Given this list of marker genes USP6, GPR50, PDE4B, AKAP5, ADD1, SPTBN1, NLGN4X, NSMF, MAGI2, PLXNC1, DLGAP1 (DLG associated protein 1), CNIH2, EIF3E, DLG1, RPS14, DLG2, DTNB, PALM (NCBI Gene Id 5064), RTN1, IGSF9, GRIK1, C1QL2, IGSF8 (immunoglobulin superfamily member 8), LRRC7, GPSM2, RPL12, SLC30A3, DAGLA, VPS35, SH3KBP1, SHISA6, SYNPO, CPEB3, LRP4, RGS7BP, HOMER3, ALS2, PTPRO, KCNH1, KALRN, GRIA3, YWHAH, GRM7, SOS1, SLC30A1, PTK2B, PLXNA4, DISC1, ABI3, ITGB1, PPP1R9B, CRTAC1, NLGN1, CASP3, GRIN1, AURKA, NCS1, CACNG8, RGS9, RPL6, LNX1, ADD3, GRID2IP, NEGR1, CAMK2D, DCC, SUMO2, GRIK3, NPTN, FRMPD2, LRRTM2, DROSHA, DGCR8, BMPR2, SYN1, ZDHHC15, FMR1, SYT9, KCNK2, NSG2, BRSK1, RPL18A, RPL8, PPP1R9A, ARHGAP32, FABP5, MIB1, SHISA8, ARC (activity regulated cytoskeleton associated protein), TAMALIN, PRKN, ATP1A1, DMTN, PDPK1 (3-phosphoinositide dependent protein kinase 1), RPLP0, ATP2B2, SLC16A7, GRIP1, AMOT, SHANK2, DLG4, DNM3, ATP7A, DBN1, GRIN2A, ELFN1, ARHGAP33, PRNP, SLC4A8, ATP1B2, ELFN2, CHRM1, RS1, LRFN4, CLSTN3, SLC6A9, SLC8A2, NECTIN3, NLGN3, ROGDI, ABL1, GPHN, SIGMAR1, CACNG7, P2RY1, P2RX3 (NCBI Gene Id 5024), PRKCG, RPS27, GRIA1, CNKSR2, DNAJC6, OPRD1, GRIN2B, TRAPPC4, ADORA1, STXBP5, DYNLL2, GOPC, CABP1, HOMER1, ANP32E, GPER1, CALB1, BNIP3, ADGRB3, NLGN4Y, ADGRA1, YWHAZ, CACNG5, ADCY1, SYT11, CPEB4, ARF1, ANKS1B, CACNA1C, LRRC4B (leucine rich repeat containing 4B), CHD4, ATP1A3, LRRC4, LRFN2, ZDHHC2, NETO1, ITGA8, GRM1, NCK2, RPL38, PTEN, PRRT2, TANC1, RYK, CLSTN2 (NCBI Gene Id 64084), LZTS3, FBXO45, RPL30, SRGAP2, DNAJB1, EGLN1, SLC39A3, TMEM108, ADCY8, SLC1A1, CTNNA2, BACE1, PLPPR4, CALCA, GRIN2C, RTN2, IGSF9B, SYN2, PSD3, GRIA2, LRFN1, CAMK2G, CACNG4, RPL10A, ERBB4, USP8, C1QL1, SEMA4C, GRIN3B, PPP3R1, BCR, NRCAM, MPP2, CAP2, MDM2, HIP1R, CHMP2B, GRIN2D, SORT1, SLITRK3, BAALC, MTMR2, TMEM240, FAM81A, MAPK8IP2, PSD (NCBI Gene Id 5662), RPL7, PAK3, EPHA4, GRIK2, GSG1L, ASIC2, PRICKLE1, DTNBP1, NETO2, EPHB2, PCBP1, ARHGAP44, C1QL3, CRHR1, GRID2, PJA2, TSC1, NGFR, BAIAP2, CAMK2N1, RUSC1, GRN, DRP2, NOTCH1, PPFIA2, ACTN2, GIT1, FYN, LRRC4C, INSYN1, MPDZ, NEO1, CAMK1, ABHD17B, ABI1, AKAP7, NECTIN1, C9orf72, PRRT1, HOMER2, CFL1, SHANK3, SAMD14, MAP2K1, RPS19, IGSF21, KLHL17, RPL14, SHANK1, SHISA9, EEF2K, IQSEC3, ADAM22, PDLIM5, ADORA2A, CDK5, SH2D5, DBNL, USP50, CACNG2 (NCBI Gene Id 10369), STAT3, STX1A, DNM2, SORCS3, DAPK1, TNIK, CRIPT, PENK, LRFN5, SYT7, EFNB2, PICK1, RPS18, SYT1, PAK2, CAMK2A (NCBI Gene Id 815), ADRA2A, SLITRK5, KPNA1, DLG5, INPP4A, PAK6, SEMA4F, ADAM10, IQSEC1, PRKAR1B (protein kinase cAMP-dependent type I regulatory subunit beta), GRIN3A, GNAI2, GRIA4, VANGL2, GRIK4, EPHA7, RNF10, ABHD17A, PRR12, BSN, SHISA7, DLG3, SLC8A1, LIN7B, GRID1, SRCIN1, SYT12, RAPGEF4, CACNG3 (calcium voltage-gated channel auxiliary subunit gamma 3), GRIK5, ADGRB1, NTSR1, LRP8, SYNGAP1, HNRNPD (heterogeneous nuclear ribonucleoprotein D), SCRIB, LIN7A, RGS14, CLSTN1, AGAP3, RNF112, CPEB1, CTNND2, MINK1, LRFN3, SPOCK1, CTNNB1, TSC2, EIF3A, NLGN2, RTN3, MKLN1, AKAP9, GRM5, UBE3B, PDYN, SH3GL3, LRRTM3, SLITRK1, NEURL1, SIPA1L1, LZTS1, NEFH, CAPZB, STRN, ARFGEF2, DGKI, NTRK2, ADD2, ABLIM1, SORCS2, RPS13, ITPR1, ARHGEF9, NAPEPLD, ABHD17C, PLEKHA5 (NCBI Gene Id 54477), EPS8, SLC8A3, RTN4, PCLO, RPS25, ASIC1, GAP43, GRM3, INSYN2A, DLGAP2, PKP4, SEMA4B, PRR7, RPS3, CSMD2, PTPRS, DLGAP3, EFNB3, LIN7C (NCBI Gene Id 55327), FGF22, SYNDIG1, RHEB, DVL1, CAMK2B, NOS1, PTPRD, SYN3, GPR158, CDK5R1, GNG3, MAP1B, here is a description of the gene set: Human Gene Set: GOCC_NEURON_TO_NEURON_SYNAPSE A synapse in which pre and post-synaptic cells are neurons. studied in species Homo sapiens